Given this list of marker genes SUCLG1, SDHB, FH, SDHC, SIRT3, ISCU (NCBI Gene Id 91850), OGDH, IDH3A, CSKMT, SDHAF4, IDH3G, IDH3B, SDHA, NFS1, ISCA1, SDHAF2, ACO2, NNT, MDH2, KGD4, ACAT1, ISCA2, FXN, TRAP1, SDHAF1, DLST, SDHD, IDH2, CS, SDHAF3, SUCLG2, DLD, LYRM4, SUCLA2, here is a description of the gene set: Reactome Pathway: Citric acid cycle (TCA cycle) part of: Aerobic respiration and respiratory electron transport In the citric acid or tricarboxylic acid (TCA) cycle, the acetyl group of acetyl CoA (derived primarily from oxidative decarboxylation of pyruvate, beta-oxidation of long-chain fatty acids, and catabolism of ketone bodies and several amino acids) can be completely oxidized to CO2 in reactions that also yield one high-energy phosphate bond (as GTP or ATP) and four reducing equivalents (three NADH + H+, and one FADH2). Then, the electron transport chain oxidizes NADH and FADH2 to yield nine more high-energy phosphate bonds (as ATP). All reactions of the citric acid cycle take place in the mitochondrion.<p>Eight canonical reactions mediate the synthesis of citrate from acetyl-CoA and oxaloacetate and the metabolism of citrate to re-form oxaloacetate. Three reactions are reversible: the interconversions of citrate and isocitrate, of fumarate and malate, and of malate and oxaloacetate. The reverse reactions are irrelevant under normal physiological conditions but appear to have a role in glucose- and glutamine-stimulated insulin secretion and cancer metabolism (e.g., Jiang et al., 2016). Succinate synthesis from succinyl-CoA can be coupled to the phosphorylation of either GDP (the canonical reaction) or ADP; we annotate both reactions. Two mitochondrial isocitrate dehydrogenase isozymes catalyze the oxidative decarboxylation of isocitrate to form alpha-ketoglutarate (2-oxoglutarate): IDH3 catalyzes the canonical reaction coupled to the reduction of NAD+, while IDH2 catalyzes the same reaction coupled to the reduction of NADP+, a reaction whose normal physiological function is unclear. Both reactions are annotated.<p>The cyclical nature of the reactions responsible for the oxidation of acetate was first suggested by Hans Krebs from biochemical studies of pigeon breast muscle. Ochoa and colleagues studied many molecular details of individual reactions, mainly by studying enzymes purified from pig hearts. While the human homologs of these enzymes have all been identified, their biochemical characterization has, in general, been limited, and many molecular details of the human reactions are inferred from those worked out in studies of the model systems. Studies examining the impact of elevated citric acid cycle intermediates such as succinate and fumarate led to the recognition of the role of metabolites in driving cancer progression ('oncometabolites'). The role of TCA enzymes in disease was reviewed by Kang et al., 2021. species: Homo sapiens